Given this list of marker genes BGN, JAM2 (NCBI Gene Id 58494), COL6A3, ROBO1, SDC1, LTBP2, SEMA3C, COL3A1, LAMA2, VCAN, NT5E, EMILIN2, TWIST2, COL6A2, TIMP1, S1PR3, SDC2, COL6A1, CXCL6, SYK, LOX, LPAR1, RDX, LTBP1, GPC1, COL5A2, FOXC2, PCOLCE2, CDH11, PCOLCE, FBN1, COL5A1, LOXL1, COL1A2, CDH2, here is a description of the gene set: species: Mus musculus Human Gene Set: CLASPER_LYMPHATIC_VESSELS_DURING_METASTASIS_DN Selected genes down-regulated during invasion of lymphatic vessels during metastasis. from publication Clasper S, Royston D, Baban D, Cao Y, Ewers S, Butz S, Vestweber D, Jackson DG (PMID 18794116) Invasion of lymphatic vessels is a key step in the metastasis of primary tumors to draining lymph nodes. Although the process is enhanced by tumor lymphangiogenesis, it is unclear whether this is a consequence of increased lymphatic vessel number, altered lymphatic vessel properties, or both. Here we have addressed the question by comparing the RNA profiles of primary lymphatic endothelial cells (LEC) isolated from the vasculature of normal tissue and from highly metastatic T-241/vascular endothelial growth factor (VEGF)-C fibrosarcomas implanted in C57BL/6 mice. Our findings reveal significant differences in expression of some genes (i.e., >or=2-fold up- or down-regulated, P <or= 0.05) that code for a variety of proteins including components of endothelial junctions, subendothelial matrix, and vessel growth/patterning. The tumor LEC profile, validated by immunohistochemical staining, is distinct from that of normal, inflammatory cytokine, or mitogen-activated LEC, characterized by elevated expression of such functionally significant molecules as the tight junction regulatory protein endothelial specific adhesion molecule (ESAM), the transforming growth factor-beta coreceptor Endoglin (CD105), the angiogenesis-associated leptin receptor, and the immunoinhibitory receptor CD200, and reduced expression of subendothelial matrix proteins including collagens, fibrillin, and biglycan. Moreover, we show similar induction of ESAM, Endoglin, and leptin receptor within tumor lymphatics in a series of human head and neck and colorectal carcinomas, and uncover a dramatic correlation between ESAM expression and nodal metastasis that identifies this marker as a possible prognostic indicator. These findings reveal a remarkable degree of phenotypic plasticity in cancer lymphatics and provide new insight into the processes of lymphatic invasion and lymph node metastasis.